The following is a description of a gene set: Human Gene Set: ZHENG_FOXP3_TARGETS_IN_T_LYMPHOCYTE_DN studied in species Mus musculus Genes with promoters bound by FOXP3 and which are down-regulated only in mature (peripheral blood) regulatory CD4+ T lymphocytes. Transcription factor Foxp3 (forkhead box P3), restricted in its expression to a specialized regulatory CD4+ T-cell subset (T(R)) with a dedicated suppressor function, controls T(R) lineage development. In humans and mice, Foxp3 deficiency results in a paucity of T(R) cells and a fatal breach in immunological tolerance, causing highly aggressive multi-organ autoimmune pathology. Here, through genome-wide analysis combining chromatin immunoprecipitation with mouse genome tiling array profiling, we identify Foxp3 binding regions for approximately genes and for an intergenically encoded microRNA. We find that a large number of Foxp3-bound genes are up- or downregulated in Foxp3+ T cells, suggesting that Foxp3 acts as both a transcriptional activator and repressor. Foxp3-mediated regulation unique to the thymus affects, among others, genes encoding nuclear factors that control gene expression and chromatin remodelling. In contrast, Foxp3 target genes shared by the thymic and peripheral T(R) cells encode primarily plasma membrane proteins, as well as cell signalling proteins. Together, our studies suggest that distinct transcriptional sub-programmes implemented by Foxp3 establish T(R) lineage during differentiation and its proliferative and functional competence in the periphery. from publication Zheng Y, Josefowicz SZ, Kas A, Chu TT, Gavin MA, Rudensky AY (PMID 17237761), and this is the list of marker genes: SCML4, BCL11B, PTBP3 (NCBI Gene Id 9991), JAK1, ST8SIA1, DPH5, LPAR6, PTGER3, LRCH1, LEF1, WIPF1, TRIM34, UTRN (NCBI Gene Id 7402), PTK2B, CMAHP, BCL2, GFI1, CLEC2D, PTPRC, ABTB2, RAPGEF6, SATB1, NRIP1, DIPK1A (divergent protein kinase domain 1A), TGFBR2, CDK17, STK10, FOXP1, SYNE2, TESPA1, NIPBL, ANKRD44, RCBTB2, PELI1, BACH2, CPE, PRAG1, WNK1